Given this list of marker genes NINJ1, ATF6, ADRM1, VTI1A, IER2, BLOC1S4, INHBA, HACE1, HBA2, MARK4, TAB2, DVL3, TTBK2, BMP15, ADH7, PTX3, C5AR1, ZMYM5, LUC7L3, SCCPDH, JMJD6, AKNA, FIGN, CCDC71L, ARID5B, CHMP3, GTF2E2, EREG, MARK3, GSR, PINK1, PLK4, CXCL13, EGR3, CSF1, ZNF436, TNFAIP6 (TNF alpha induced protein 6), NUP58, PIBF1, CST7, PRDM1, SOCS4, BCLAF1, CRLF3, P2RY2, PENK, CPSF4 (cleavage and polyadenylation specific factor 4), PCNX1, CENPF, PPBP, ATG9B, ANKRD2, MC1R, GINM1, RTN1, PROM2, SLC22A8, SPATA13, MARCKSL1 (MARCKS like 1), ABCF2, TAF7, PXMP2, IK, THNSL2, CD14, SUCO, MIS12, SNTB1, JARID2, ZBTB7A, GRIA2, TAMALIN, TPBG, TM6SF2, PACRG, RASA2, TBX4, CLYBL (NCBI Gene Id 171425), COPG1, HES2, ELL2, BRD2, REM1, RUFY3, CHADL, GRAMD1A, ILK (integrin linked kinase), CFLAR, GSTZ1, CCRL2, YRDC, AREG, APOA2, PELI1 (NCBI Gene Id 57334), GHRL, CCNB2 (NCBI Gene Id 9133), SOCS2, ADAMTS8, CRTC2, ICAM1, FABP6, GCH1, KLHL25, CCT6A, CHRNA2, NCK1, KICS2, HCAR2, KIF1A, WNT7B, GDPD1, GABRD, ST6GALNAC4, JUNB, TRPM5, SHROOM3, ZC3H7A, MEIS3, ZFP57, RNF208, KLK4, CLCF1, CDKN1A, TGFB2, NUPR1, ZNF280D, ZNF146, PLAA, RIPK1, SORCS1, NEDD1, DLX2, MIDN, MRPL4, GPANK1, NPR2, FDFT1, DYRK1B, NMT1, LDHC, KCNH2, AACS, ANKRD33, CHKA, ENKD1, BATF3, PPP1R15A, KRTAP13-2, CES1 (carboxylesterase 1), NSDHL, RRH, PYGM, VCP, ADRB3, MED25, BCAM, GLYCTK, MYH7, OTOR, TUT1, IFIT1B (NCBI Gene Id 439996), ZNF771, FOXB1, RNF111, ELF2, NOP58, CRBN, RASAL2, RNGTT, ID2 (inhibitor of DNA binding 2), DAPK1, TSGA13, FAM98C, GNA13, CLINT1, MYO5A, GJD2, RANBP10, ASB12, KLF1, ABCC1, TLNRD1, RAB30, PCDHAC1, CXCL11, MTMR7, RAI14, PRRX2, UBE3A, UBXN2A, GPR84, CPD, UGT8, TPR, SYF2, ENDOD1, RANBP3, TSC1, IER5, SPMIP10, here is a description of the gene set: from publication Amit I, Garber M, Chevrier N, Leite AP, Donner Y, Eisenhaure T, Guttman M, Grenier JK, Li W, Zuk O, Schubert LA, Birditt B, Shay T, Goren A, Zhang X, Smith Z, Deering R, McDonald RC, Cabili M, Bernstein BE, Rinn JL, Meissner A, Root DE, Hacohen N, Regev A (PMID 19729616) Genes down-regulated in comparison of control dendritic cells (DC) at 2 h versus those stimulated with poly(I:C) (TLR3 agonist) at 2 h. mouse primary BMDCs were stimulated with tlr ligands and gene expression changes were profiled on Affymetrix arrays Human Gene Set: GSE17721_CTRL_VS_POLYIC_2H_BMDC_DN species: Homo sapiens